Given this list of marker genes HS3ST3A1, BMPR2, HS3ST6, HS3ST3B1, GLCE, B4GALT7, HS6ST2, CSGALNACT2, HS6ST3, ANGPT1, SLC10A7, HS3ST4, ST3GAL1, TM9SF2, SLC35D2, ST3GAL4, ST3GAL2, NDST3, CANT1, EXT2, NDST4, HS3ST5, CHST12, CHST6, B3GNT4, EXTL2, NDST2, GAL3ST4, SLC2A10, CHSY3, B4GALT4, FAM20B, EXTL3, CHSY1, B3GALT6, IGF1, XYLT2, NDST1, EXTL1, CHST13, CHST2 (carbohydrate sulfotransferase 2), B4GAT1, MUSTN1, CHST11, UST, B3GAT2, CHST9, HS3ST1, CTNNB1, UGDH, DSE, TCF7L2, XYLT1, CHPF2, CHST14, CHPF, HS2ST1, B3GNT2, CSGALNACT1, CHST3, B3GAT3, HS3ST2, B3GAT1, EXT1, CHST5, VANGL2, CHST8, CHST1, FOXL1, GAL3ST3, PXYLP1, ST3GAL6, CHST7, B3GNT7, CYTL1, BMPR1B, HS6ST1, ST3GAL3, CHST10 (carbohydrate sulfotransferase 10), B3GNT3 (UDP-GlcNAc:betaGal beta-1,3-N-acetylglucosaminyltransferase 3), SLC35B2, here is a description of the gene set: Human Gene Set: GOBP_PROTEOGLYCAN_BIOSYNTHETIC_PROCESS species: Homo sapiens The chemical reactions and pathways resulting in the formation of proteoglycans, any glycoprotein in which the carbohydrate units are glycosaminoglycans.